Given this list of marker genes SLC12A3, here is a description of the gene set: part of: SLC transporter disorders Reactome Pathway: Defective SLC12A3 causes Gitelman syndrome (GS) studied in species Homo sapiens The SLC12A3 gene encodes for the Thiazide-sensitive sodium-chloride cotransporter (TSC). TSC mediates sodium and chloride removal from the distal convoluted tubule of the kidney. Defects in SLC12A3 are the cause of Gitelman syndrome (GS aka familial hypokalemic hypomagnesemia; MIM:263800). GS is an autosomal recessive disorder characterised by hypokalemic metabolic alkalosis, hypomagnesemia, and hypocalciuria. Patients can present with periods of muscular weakness and tetany, usually accompanied by abdominal pain, vomiting and fever. GS has overlapping features with Bartter syndrome (caused by defects in SLC12A1). This cotransporter is the major target for thiazide-type diuretics, used in the treatment of hypertension, extracellular fluid overload and renal stone disease.